The following is a description of a gene set: Ecteinascidin 743 (ET-743; Yondelis, Trabectedin) is a marine anticancer agent that induces long-lasting objective remissions and tumor control in a subset of patients with pretreated/resistant soft-tissue sarcoma. Drug-induced tumor control is achievable in 22% of such patients, but there is no clear indication of the molecular features correlated with clinical sensitivity/resistance to ET-743. Nine low-passage, soft-tissue sarcoma cell lines, explanted from chemo-naive patients with different patterns of sensitivity, have been profiled with a cDNA microarray containing 6,700 cancer-related genes. The molecular signature of these cell lines was analyzed at baseline and at four different times after ET-743 exposure. The association of levels of TP53 mutation and TP73 expression with ET-743 sensitivity and cell cycle kinetics after treatment was also analyzed. Gene expression profile analysis revealed up-regulation of genes and down-regulation of genes in response to ET-743. The ET-743 gene expression signature identified a group of genes related with cell cycle control, stress, and DNA-damage response (JUNB, ATF3, CS-1, SAT, GADD45B, and ID2) that were up-regulated in all the cell lines studied. The transcriptional signature 72 hours after ET-743 administration, associated with ET-743 sensitivity, showed a more efficient induction of genes involved in DNA-damage response and apoptosis, such as RAD17, BRCA1, PAR4, CDKN1A, and P53DINP1, in the sensitive cell line group. The transcriptional signature described here may lead to the identification of ET-743 downstream mediators and transcription regulators and the proposal of strategies by which ET-743-sensitive tumors may be identified. Human Gene Set: MARTINEZ_RESPONSE_TO_TRABECTEDIN_DN species: Homo sapiens Genes down-regulated in at least 8 of 11 sarcoma cell lines by trabectedin. from publication Martínez N, Sánchez-Beato M, Carnero A, Moneo V, Tercero JC, Fernández I, Navarrete M, Jimeno J, Piris MA (PMID 15897246), and this is the list of marker genes: MTMR4, ZDHHC5, UBR7 (NCBI Gene Id 55148), KIFBP, LUZP1, PRIM2, LSM14A, GDI2, IPO7, ANLN, EMSY, UBN1 (ubinuclein 1), DTL, RAB5A, DIS3, CORO1C, RNF220, NOC3L, MTCL1, SUPV3L1, STK17B, BIRC6, CMPK1, PPP2R1B (protein phosphatase 2 scaffold subunit Abeta), CDH11, CPSF7, UBE2T, FYN (FYN proto-oncogene, Src family tyrosine kinase), WEE1, MAP3K7, SNIP1, PHF6, USP22, EP400, MED17, MYC, STAU1, MAP7D3, HDAC2, MAPKAPK5, GOPC, RSPRY1, TOP1, PTGES3, TOP2A, IMMP2L, PEX1, PLAG1, CCN2, PSMA5, PTPRK, OSBP, CLCN7, CDC25C, VEGFC, PDGFB, BTAF1, TMEM248, ATG5, CFLAR, SLC2A1, PSME3, NPAS2, ARFGEF2, AURKA, ZMYM2, TMPO, PJA2, LRRC8C (NCBI Gene Id 84230), RCOR1, EML4, CDK7, DNAJA2, SRSF9, EPB41, CDC23, FRYL, RAP1B, CDK1, PRKACB, KIF11, BUB3, FNDC3A, MTIF2, RCC1, TXNRD1, BIRC2, FOXK2, UBE2C, TRIP4, RAD23B, RBM27, THRAP3, HSPE1, ZNF281, SPRY2, ITPRID2, ZDHHC16, RABGAP1, TDG, CRK, PSMC6, HSPA8, MAGEF1, TBL1XR1, ARPC5L, GGPS1, RBM14, ELOVL6, USP8, GABPB2, PAFAH2, TARDBP, FNTA, NLRC4, FAF1, PSMB1, PAMR1, NCOA6, CCNA2, RABGGTB, SQSTM1, PPP2R5E, RAB6A, PSMG2, MAP3K4, ARFGAP1 (NCBI Gene Id 55738), RSRC2, FKBP15, CDC42BPA, BCL2L1 (BCL2 like 1), CDIN1, MAT2A, ZNF345, B4GALT5, CDK5R1, GTF2H2, MACIR, TIAM2, BUB1 (NCBI Gene Id 699), ZMYND8, CCNH, DDX20 (NCBI Gene Id 51452), DCK, NET1, CCT4, ZNHIT3, SON, CDC27, PKN2, EPS8, FZD1, CDC5L, EGFR, RBM25, DDX21, BLZF1, LBR, POLD3 (NCBI Gene Id 10714), FADD, MRPS35, OSBPL9, TSPAN14, EPS15 (epidermal growth factor receptor pathway substrate 15), H4C2, CXXC5, RIPK1, HERC4, RNF14, WNT5B, GTF2B, TCERG1, KDM4B, MYCBP2, RAD54B, BTG1, JAG1, KDM1A, HS3ST3B1, TGIF1, GCC2, TIMM21, PANX1, METTL13, SRPK2, PSMC2, SRRM2, FBXL3, DKC1, TRIM24, GAPVD1, RAB2A, NBN, SMARCA5, EIF3A, MAPK14, SIRT1, SACS, HSPA1L, XBP1, PLK1, BAG2 (NCBI Gene Id 9532), SRSF4, ADSL, ARHGEF2, VPS35L, DLG5, GLRX, ABRAXAS2, TMEM138, SLC4A1AP, MRPL1, ZFTRAF1, FOSL1, USP12, LRRC42 (NCBI Gene Id 115353), DNAAF2, XRCC5, CRLF3, LHFPL2, TSFM, MRPL15, MCTS1, HSPH1, NUFIP1, JMJD1C, STK17A, UBE2D3, TMEM53, GTF2H1, MCM3, SERBP1, OGT, YWHAE, MFAP1, SRSF3, MID1IP1, PPP1CC, UBA2, ERCC3, CSNK2A1, ACSL3, RPP14, SLC25A17, TARBP1, UCK2, IGF2BP2, CEP55, UBE2D2, SAMD4A (NCBI Gene Id 26078), USP3, TP53INP1, MICAL2, C8orf76 (NCBI Gene Id 84933), MEAF6, NMI, FBXL7, RBM17, PRKD3, VCAN, PCNA, SIRPA, ATF1, SEC16A, SPIN1, EIF4B, TBK1, RAB1A, PSMA4, SYNE1, PSMD14, H4C3